Given this list of marker genes Fxyd7, Lin28b, H2-T3, Pvalb, Hoxb13, Islr2, Ttll6, Rgs8, Esrp1, Matn1, Pou2af1, Mlph, Cfap65, here is a description of the gene set: from publication Mikkelsen TS, Ku M, Jaffe DB, Issac B, Lieberman E, Giannoukos G, Alvarez P, Brockman W, Kim TK, Koche RP, Lee W, Mendenhall E, O'Donovan A, Presser A, Russ C, Xie X, Meissner A, Wernig M, Jaenisch R, Nusbaum C, Lander ES, Bernstein BE (PMID 17603471) Genes with intermediate-CpG-density promoters (ICP) bearing histone H3 trimethylation mark at K27 (H3K27me3) in neural progenitor cells (NPC). species: Mus musculus Mouse Gene Set: MIKKELSEN_NPC_ICP_WITH_H3K27ME3 We report the application of single-molecule-based sequencing technology for high-throughput profiling of histone modifications in mammalian cells. By obtaining over four billion bases of sequence from chromatin immunoprecipitated DNA, we generated genome-wide chromatin-state maps of mouse embryonic stem cells, neural progenitor cells and embryonic fibroblasts. We find that lysine 4 and lysine 27 trimethylation effectively discriminates genes that are expressed, poised for expression, or stably repressed, and therefore reflect cell state and lineage potential. Lysine 36 trimethylation marks primary coding and non-coding transcripts, facilitating gene annotation. Trimethylation of lysine 9 and lysine 20 is detected at satellite, telomeric and active long-terminal repeats, and can spread into proximal unique sequences. Lysine 4 and lysine 9 trimethylation marks imprinting control regions. Finally, we show that chromatin state can be read in an allele-specific manner by using single nucleotide polymorphisms. This study provides a framework for the application of comprehensive chromatin profiling towards characterization of diverse mammalian cell populations.